The following is a description of a gene set: Human Gene Set: HP_ABNORMAL_SPERM_AXONEME_MORPHOLOGY studied in species Homo sapiens Abnormal sperm axoneme morphology Abnormal structure of the sperm axonemal structure which consists of a ring of nine microtubular doublets and a central pair of microtubules, giving the classical 9+2 microtubular arrangement. The axoneme contains a central pair of microtubules (C1 and C2) that are connected by a bridge-like structure forming the central pair complex (CPC). Each of the nine outer doublets is composed of type A and B microtubules and connected by radial spokes to the CPC., and this is the list of marker genes: USP26 (ubiquitin specific peptidase 26), QRICH2, CFAP91, SPEF2, FSIP2, CATIP, AK7, WDR19